Given this list of marker genes TMCC3, THUMPD1, CYB561A3, ATG5, CRNKL1, NAA25, RNF139-DT, STAT6, ESRP2, NFX1, MEN1, ABCB8, LIAT1, DDX39B-AS1, TNPO1-DT, NME7, SRSF10, ZMPSTE24-DT, ENSG00000235480, TOB1-AS1, RAB3D (NCBI Gene Id 9545), ABHD10, ULK4, NAA30, C11orf71, NFYA, CDC26, SNORD84, CSNK1G1, MTF2, SPRTN, PHLDA1, ORC2 (origin recognition complex subunit 2), RPL39L, EVA1C, ENY2, CASC3, RBM34, OIP5, DCAKD (NCBI Gene Id 79877), NMT1, ABI1, RPRD2, IQANK1, TMEM14A, HSPA8 (heat shock protein family A (Hsp70) member 8), LRRCC1, LARP7, TMEM62, CXXC1, BROX, TDP1, KRT18, FAN1, H4C8, BCAS2, NUSAP1, ATP6V1D, PHLDA1-DT, SARM1, RPUSD4, DCP1B, TMEM205, ULBP3, PAXBP1, SKP1, MYCBPAP, MEPCE, MCMBP, WDR89, NUDCD1, SAP18, DNAJC9-AS1, INTS13, KRT8, ATF4, IRF2BP1, ID2, BCDIN3D, DCAF7, TTC32, TM4SF4, DDX41, SPNS1, SQSTM1, NPAT, TSGA10, DNAI7, UBAP2 (ubiquitin associated protein 2), ATP10D (NCBI Gene Id 57205), MIR3913-1, CENPM, BRF2, HARS2, RBM12B, C2CD5, RIT1, ATXN2, PNO1, SLC28A2-AS1, QTRT1, GPSM3, CHTOP, ID2-AS1, GPR39, TBCB, FAM133B, POC1B-GALNT4, PLEKHJ1, ZMPSTE24, IDH1, PCDH1, ESRP1, FEM1A, ZCCHC4, DDX39B, MAP3K14, EFCAB15P, EIF2S1, ATM (NCBI Gene Id 8068), ITPR1-DT, SS18, NDUFA3, POU6F1, CCT2, GDAP2, MAP3K14-AS1, ARFIP2, RBM12B-DT, ANKRD26, PRDX5, CYC1, PRPF4, HSD17B4, ZDHHC17, PTMA, EEF1B2, ZCWPW1, PSMD14, MTRFR, KBTBD2, TIMM10B, GSTK1 (glutathione S-transferase kappa 1), ZNF584, USP53, LDAH, NDUFS1, HOXC-AS2, COQ8B (NCBI Gene Id 79934), OARD1, RPL27A, AP3B1, SEC16B, FRS3, SNORD101, IFNAR1, ATOSB, INTS14, ZGRF1, TMEM18, SEC23IP, CSPP1 (NCBI Gene Id 79848), H4C1, RBBP8, STAM2, ZBTB41, UBQLN1, PCNP, FBXL12, CDKN1B, TMEM138, POU2F1-DT, MPHOSPH10, FOXP2, ARID3B, VANGL1, TTC32-DT, TMBIM4, LINC01635, PARAIL, RBAK-RBAKDN, SAR1B, SMARCA4, BRAP, NABP2, CZIB, POU2F1, SLC35C1, CFAP68, ENSG00000241525, NBEAL1, SOCS2, CZIB-DT, LINC02405, TUBD1, CAGE1, ZBTB37, HSDL2, KCNIP2-AS1, RECQL5, RPS29, DSE, CFAP61, NOL7, GGCX (gamma-glutamyl carboxylase), ENSG00000232876, EBAG9, COPS5, CCT4, PCSK9, POC1B, CRNDE, SUPT4H1, MRPL42P1, HMGB1, SLC25A39, TOMM6, ACAD9, BLZF1, CCDC159, ANAPC7, LIPT1, CDIN1, PIK3R3, AIDA, ETFBKMT, PNISR, MYG1, RBM7, RPL4, EPCIP-AS1, EIF3E, SARNP, GAS5, TRMO, DHX40, APTR, EIF1, STK40, LURAP1L-AS1, FAM118B, EXOC8, RPL31, RPS12, FDXACB1, HNRNPH3, GSTO2, RSU1, RIOK1, RPL5, FGFR1OP2 (NCBI Gene Id 378428), DNAAF10, SF3B4, POLR2I, SF3A2, COMMD1, CDK4, RBM22, C22orf46P, UBE2I, LENG9, LINC00339, GANC, SLC52A3, ERLEC1, OSCAR, SNORA70, RNF139, OGA, RPL15 (ribosomal protein L15), C19orf53, KAZALD1, HBS1L, METRNL, SNRPE, ORMDL2, PCBP2, SINHCAF, RAD51-AS1, HARS1, H2BC15, FZD1, RBAK, PIK3C2B, NKIRAS1, BAG6, RAP2B, TRIM26, SCAF11, ZWILCH, SLC24A1, SAP30BP, H4C13, PSMD9, WDR59, CLCN3, AGPAT1, RNU4ATAC, PSMD14-DT, ACAD10, TSPYL1, PIKFYVE, ASB3, VAMP8, TRMT13, CLASP1, LRR1, SEC31A, SDE2, GON7, NDUFV3, HSPA5, SAMD4A (NCBI Gene Id 26078), RNF41, ETFRF1, GOSR1, RAD51, WDR12, TOB1, WDR4, TMEM87A, RSBN1L, AGR2, RPH3AL-AS2, GCNT3, UBR7, NOL6, GCHFR, RPS6KB1, MIEF2, MMADHC-DT, here is a description of the gene set: from publication Yevshin I, Sharipov R, Kolmykov S, Kondrakhin Y, Kolpakov F (PMID 30445619) Human Gene Set: ZNF581_TARGET_GENES Genes containing one or more binding sites for (ZNF581) in their promoter regions (TSS -1000,+100 bp) as identified by GTRD version 20.06 ChIP-seq harmonization. studied in species Homo sapiens